The following is a description of a gene set: studied in species Homo sapiens TGF-beta3 produced by developing Th17 cells induces highly pathogenic T cells that are functionally and molecularly distinct from TGF-beta1-induced Th17 cells. The microarray data represent a distinct molecular signature for pathogenic versus non-pathogenic Th17 cells. Genes up-regulated in comparison of untreated CD4 T cells versus those treated with IL1B and IL6. from publication Lee Y, Awasthi A, Yosef N, Quintana FJ, Xiao S, Peters A, Wu C, Kleinewietfeld M, Kunder S, Hafler DA, Sobel RA, Regev A, Kuchroo VK (PMID 22961052) Human Gene Set: GSE39820_CTRL_VS_IL1B_IL6_CD4_TCELL_UP, and this is the list of marker genes: STON1, CD83, PLA1A, STK39, DAPL1, HYAL2, BEX1, LEF1, JMJD4, ASAP1, EOMES, TIMMDC1, IKZF2, ATP1A1, HMGCS1, NSG1, ITGA6, ABCB1, MAOA, ANKRD44, IDI1 (NCBI Gene Id 3422), MYB, PHTF2, PPP1R16B, FASLG (Fas ligand), TLR1, RBMX, DCDC2B, COPS7A, IPPK, LIN7A, CCT3, SBF2, TLK1, NSDHL, DUSP4, CNOT6, PLAGL1, FIRRM, C12orf75, NUCKS1, RELL1, ASAH1, PTER, MINDY2, BUB3, NCAPG2, NCF1, SCIN, PFAS, TNNI1, DCUN1D3, AMPD2, ST3GAL2, ZNF213, PLXND1, DENND1B, PACSIN1, IFT80, GPATCH4, HMGCR, TMEM243, ALG8, SAMD9L, FAM111A, TENT5A, NTRK3, RSRC1, PHC3, MAP3K8, KDM5C, IPCEF1, PDCD4, PARP1, GAP43, MBNL3, SH2D1A, CARNMT1, USP31, RBM12, SIK1, PENK (proenkephalin), FAM98B, XIST, PPM1B, ACTB, ITGA4, CDH16, METTL8, STYX, UBASH3A, TSPAN13, CUL4B, PBDC1, RNF41, STARD4, HLA-DQA1, FANCF, CIP2A, ST8SIA6, DOCK10, APOBEC1, DUSP5, MID1, MAT2A, PUS7L, C10orf88, HSPA8, CDIP1, CYP51A1, COX17, MRPS2, L2HGDH, OAZ1, NRP1, CDC40, DDX3X, CMTM7, HNRNPAB (NCBI Gene Id 3182), SLC23A2, LARP4, CSNK1A1, FADS2, SMC3, SQLE, BLM, FAM83D, PIK3R1, PKIB, AP4M1, SCD, GPR34, MTRR, FOXN3, HSD17B7, NUP133, SKP2, RUFY3, EXO1 (exonuclease 1), LAD1, METRNL (NCBI Gene Id 653506), CBX4, UBR1 (ubiquitin protein ligase E3 component n-recognin 1), NCOA7, ELL2, CD96, ERCC6L, STAG2, IGHM, RRM2, DNAJC30, METAP2, KDM6A, TNIK, ANKRD6, PGM2L1, SOCS5, TMEM131L, ANKRD33B, TESK2 (NCBI Gene Id 96574), CSF2, INSIG1, PIGG, PIK3CG, ERGIC1, FASN, ATP8B4, PHLDA1 (NCBI Gene Id 22822), AACS, HECA, ZNF770, RPIA, C1QTNF12, DNMT3B, ARL5A, RCSD1, SLC35B4, DTWD2, GPD1L, ERCC1, DDX31 (NCBI Gene Id 64794), GSTO1, PUS3, IL13, REG1B, ATP11C, DLAT, IVD, ITPR1, TCF3, ARHGAP31, CHML, S1PR3, KRIT1, POLR1B, RHOD, PTGER4, ATIC, TBC1D4